The following is a description of a gene set: studied in species Homo sapiens The gene expression program underlying the specification of human cell types is of fundamental interest. The study authors generated human cell atlases of gene expression and chromatin accessibility in fetal tissues. For gene expression, the study authors applied three-level combinatorial indexing to >110 samples representing 15 organs, ultimately profiling ~4 million single cells. The study authors leveraged the literature and other atlases to identify and annotate hundreds of cell types and subtypes, both within and across tissues. Our analyses focused on organ-specific specializations of broadly distributed cell types (such as blood, endothelial, and epithelial), sites of fetal erythropoiesis (which notably included the adrenal gland), and integration with mouse developmental atlases (such as conserved specification of blood cells). These data represent a rich resource for the exploration of in vivo human gene expression in diverse tissues and cell types. from publication Cao J, O'Day DR, Pliner HA, Kingsley PD, Deng M, Daza RM, Zager MA, Aldinger KA, Blecher-Gonen R, Zhang F, Spielmann M, Palis J, Doherty D, Steemers FJ, Glass IA, Trapnell C, Shendure J (PMID 33184181) Human Gene Set: DESCARTES_FETAL_EYE_VASCULAR_ENDOTHELIAL_CELLS Marker genes curated from the annotated cluster as represented in the Descartes Human Gene Expression During Development database., and this is the list of marker genes: ABCB1, ABCG2, APLNR, GGT5, SMAD7, SOX18 (SRY-box transcription factor 18), RGCC, ECSCR (endothelial cell surface expressed chemotaxis and apoptosis regulator), APOL3, CLDN5, CETP, SHANK3, FGD5, THSD1, STARD8, PKD1L1, MYCT1, UPB1, ELK3 (NCBI Gene Id 2004), ICAM2, PDE2A, TINAGL1, FLT4, LINC02147, FLT1, GIMAP4, DUSP6, TCIM, ADGRL4, FAM124B, TIE1 (NCBI Gene Id 7075), ADGRF5, S1PR1, NOS3, PCAT19, VASH1, CALCRL, RASIP1, ARHGEF15, PODXL, ERG, PRKCH, PPP1R14A, MLKL, SELP, TM4SF18, ZNF366, EGFL7, ATG9B, ROBO4, ARL15, ADCY4 (NCBI Gene Id 196883), MPL, ST8SIA6, PLXND1, RAMP2, TAMALIN, IHH, ALPL, TEK, CDH5, GIMAP1, HAPLN1, HAPLN3, LXN, ENG, KANK3, CLEC14A, BTNL8, ARHGAP29, RAMP3, SOX7, CLEC1A, NOTCH4, RXFP1, ADORA2A-AS1, ENSG00000248636, LINC03033, PLVAP, EPAS1, SEMA3G, ACVRL1, LRRC32, GOLGA8M, BEND4, VWF, CYP26B1, USHBP1, CAVIN2, QRFPR (pyroglutamylated RFamide peptide receptor), DIPK2B, CCM2L